The following is a description of a gene set: Alveolar rhabdomyosarcomas (ARMS) are aggressive soft-tissue sarcomas affecting children and young adults. Most ARMS tumors express the PAX3-FKHR or PAX7-FKHR (PAX-FKHR) fusion genes resulting from the t(2;13) or t(1;13) chromosomal translocations, respectively. However, up to 25% of ARMS tumors are fusion negative, making it unclear whether ARMS represent a single disease or multiple clinical and biological entities with a common phenotype. To test to what extent PAX-FKHR determine class and behavior of ARMS, we used oligonucleotide microarray expression profiling on 139 primary rhabdomyosarcoma tumors and an in vitro model. We found that ARMS tumors expressing either PAX-FKHR gene share a common expression profile distinct from fusion-negative ARMS and from the other rhabdomyosarcoma variants. We also observed that PAX-FKHR expression above a minimum level is necessary for the detection of this expression profile. Using an ectopic PAX3-FKHR and PAX7-FKHR expression model, we identified an expression signature regulated by PAX-FKHR that is specific to PAX-FKHR-positive ARMS tumors. Data mining for functional annotations of signature genes suggested a role for PAX-FKHR in regulating ARMS proliferation and differentiation. Cox regression modeling identified a subset of genes within the PAX-FKHR expression signature that segregated ARMS patients into three risk groups with 5-year overall survival estimates of 7%, 48%, and 93%. These prognostic classes were independent of conventional clinical risk factors. Our results show that PAX-FKHR dictate a specific expression signature that helps define the molecular phenotype of PAX-FKHR-positive ARMS tumors and, because it is linked with disease outcome in ARMS patients, determine tumor behavior. Human Gene Set: DAVICIONI_PAX_FOXO1_SIGNATURE_IN_ARMS_UP studied in species Homo sapiens 'PAX-FKHR signature': genes up-regulated by PAX3- or PAX7-FOXO1 fusion in primary alveolar rhabdomyosarcoma(ARMS) tumors. from publication Davicioni E, Finckenstein FG, Shahbazian V, Buckley JD, Triche TJ, Anderson MJ (PMID 16849537), and this is the list of marker genes: KCNN3, KCNS3, MARCHF3, NMRK1, TMEFF1, PBK (NCBI Gene Id 55886), PSEN2, VWA5A, SULF1 (sulfatase 1), COL18A1, PRKAR2B, MET, PON2, JAKMIP2, DCX, IL4R, GPM6B, MYOD1, NELL1, TBC1D9, INPP1, RASL10A (NCBI Gene Id 10633), ALK, BMP5, ARRB1, ARL4C, ADAM10, TMEM47, ANK2, PAX5, MAP1LC3B, MYO18A, SGK1 (serum/glucocorticoid regulated kinase 1), TMX4, MEG3 (maternally expressed 3), TNFAIP3, ACKR3, FGFR4, IRS2, NRCAM, TNS3, ASS1, SPATS2L, GADD45A (NCBI Gene Id 1647), NEBL, FMR1, SKP2, ABAT, PPP1R14B, TCF7L2, MN1 (MN1 proto-oncogene, transcriptional regulator), HDAC5, POU4F1, MORC4, PRKCA, MYCN, WSB2, CD9, TRAM2, LSP1P5